The following is a description of a gene set: species: Mus musculus Cytolysis of target cells by natural killer cells, eosinophils, neutrophils, monocytes, or macrophages following engagement of antibodies bound to the target cells by Fc receptors on the effector cells. Mouse Gene Set: GOBP_ANTIBODY_DEPENDENT_CELLULAR_CYTOTOXICITY, and this is the list of marker genes: Ighg1, Fcgr1, Fcgr4, Fcgr2b, H2-T23, Fcgr3, Ighe